Given this list of marker genes ITPR1, ZMYM2, ARHGAP31, RIPK4, TBX3, here is a description of the gene set: A congenital disorder where the hymen (a membrane that surrounds or partially covers the external vaginal opening) does not have an opening and completely obstructs the vagina. studied in species Homo sapiens Human Gene Set: HP_IMPERFORATE_HYMEN Imperforate hymen